The following is a description of a gene set: studied in species Homo sapiens Human Gene Set: GSE29949_DC_BRAIN_VS_MONOCYTE_BONE_MARROW_UP Genes up-regulated in brain dendritic cells versus bone marrow monocytes. To understand the functional relationship between brain dendritic cells (brain DCs) and other myeloid cells, we compared the gene expression profile of m/chDCs to that of bone marrow monocytes, brain microglia and classical spleen CD8+ and CD8- DCs. In order to obtain enough brain DCs for mRNA extraction, we expanded brain DCs with in vivo Flt3L treatment before purification. from publication Anandasabapathy N, Victora GD, Meredith M, Feder R, Dong B, Kluger C, Yao K, Dustin ML, Nussenzweig MC, Steinman RM, Liu K (PMID 21788405), and this is the list of marker genes: CNN3, INE2, PLCB3, NBEAL2, TUBGCP3, NF1, TUBB, DIDO1, IL1RAP, EMC1, SLC5A3, SLC25A14, DGAT1, VAT1, LGALS1, MMUT, KRT13, CAPN2, CAPG, MGST3, TAX1BP1, GSTO1, MBTPS1, ERG28, ERCC1, IL10RA, ACVR1, SRD5A1, ATP6V0A2, MEGF9, ACOT8, SLC35B1, SMARCE1, SYNJ2, QSOX1, CDIPT, ASCC2, ETFB, NRDC, PHYH, PF4, SULT2A1, AHNAK, CBFB, UBE2I, BATF, RSU1, RGS19, COL4A4, ZHX3, KLF7, UBE2V2, ACADVL, CYP2B7P, CXCR3, SKAP2, SS18, PLOD2, GNG5, REEP5, DUSP6, NORAD, KDELR2, REXO5, PKIA, BYSL, BAG5, TASOR, STAM2, S100A11, SETD4, EFNB1, SYT11, SPINT2, KIF14, FAM193A, VAMP8, GCNT1 (glucosaminyl (N-acetyl) transferase 1), SMCHD1 (structural maintenance of chromosomes flexible hinge domain containing 1), MAP3K14, UCN, RGS16, POLD2, LRP5, JAK3, MICAL2, FLNA, SLC16A1, SUSD6, RBM14, FUT8, NKG7, PAK1, TRMT1, ACD, TRIP13, PMF1, MAPK1, SAMM50, KLHDC3, SLC17A4, ACSL1, CD47, AURKC, CCL5, ARHGAP11A, ESYT1, PLA2G4C, SNAP23, FAM89B, BMP4, SACS, IL2RB, CLASP1, PLIN3, GATA3, MKNK1, EXD2, PIWIL1 (NCBI Gene Id 9271), FOXO1, SIPA1, SOCS1, ITGA4, NSD2, ABR, ATG4A, RYBP, BASP1, MYH9, F9, PSD4, ATP2B1, EHHADH, VLDLR, ITGAE (NCBI Gene Id 3682), COL6A3, SERPINB6, PLP2 (NCBI Gene Id 5355), PDS5B, ATP1B1, CYLD, GTF2H5, SLC39A14, ATP5F1A, SCEL (NCBI Gene Id 8796), NTRK1, BEAN1, XYLT1, TRBC1, SMAD2, ADCY7, KDM2A, ARF3, TM9SF2, TUBB2A, RRS1, RALB, AOAH, CHRNA6, UPP1, DIXDC1, PRAF2, STK17B, CYBA, CTNS, TAF5L, GALK2, MCM7, MAPK14, CD2, TP63, PIEZO1 (piezo type mechanosensitive ion channel component 1 (Er blood group)), SLC20A2, NADK, ADD1, GTF2E1, GNAI2, TSC2, ZNF160, PIP4K2A, VIPR1, RAB5A, C11orf58, CSRNP2, CLUL1, IKBKG (inhibitor of nuclear factor kappa B kinase regulatory subunit gamma), SATB1, HARS2, H4C2, SCN9A, GAB1, AMPH, DPYSL2, NFX1, LARS2, PTPRA, DNAJC7, ANKS1A, SPART